Given this list of marker genes ODC1, PRRT2, SCN1A, MEN1, STX1B, GRIN2A, SCN1B, SCN9A, CDKN2B, CDKN1A, GABRD, GABRG2, HCN1, SCN2A, FGF13, CDKN2C, CDKN1B, ADGRV1, POLG, DNM1 (dynamin 1), here is a description of the gene set: A type of status epilepticus without prominent motor symptoms in the absence of coma. Non-convulsive status epilepticus without coma studied in species Homo sapiens Human Gene Set: HP_NON_CONVULSIVE_STATUS_EPILEPTICUS_WITHOUT_COMA